Given this list of marker genes RPS21, BMS1, RRS1, TBL3, NOL9, UTP20, FCF1, RCL1, SDE2, KRI1, TSR1, NOP14, BOP1, ABT1, UTP23, NOP9, RPP40 (ribonuclease P/MRP subunit p40), here is a description of the gene set: Endonucleolytic cleavage of a pre-rRNA molecule originally produced as a tricistronic rRNA transcript that contains the Small SubUnit (SSU) rRNA, the 5.8S rRNA, and the Large SubUnit (LSU) rRNA, in that order, from 5' to 3' along the primary transcript. Primary ribosomal RNA transcripts with three genes, in this order, are produced in the nuclei of many eukaryotic species, including S. cerevisiae. Human Gene Set: GOBP_ENDONUCLEOLYTIC_CLEAVAGE_OF_TRICISTRONIC_RRNA_TRANSCRIPT_SSU_RRNA_5_8S_RRNA_LSU_RRNA species: Homo sapiens